The following is a description of a gene set: Human Gene Set: MYLLYKANGAS_AMPLIFICATION_HOT_SPOT_21 from publication Myllykangas S, Himberg J, Böhling T, Nagy B, Hollmén J, Knuutila S (PMID 16751803) studied in species Homo sapiens DNA copy number amplifications activate oncogenes and are hallmarks of nearly all advanced tumors. Amplified genes represent attractive targets for therapy, diagnostics and prognostics. To investigate DNA amplifications in different neoplasms, we performed a bibliomics survey using 838 published chromosomal comparative genomic hybridization studies and collected amplification data at chromosome band resolution from more than 4500 cases. Amplification profiles were determined for 73 distinct neoplasms. Neoplasms were clustered according to the amplification profiles, and frequently amplified chromosomal loci (amplification hot spots) were identified using computational modeling. To investigate the site specificity and mechanisms of gene amplifications, colocalization of amplification hot spots, cancer genes, fragile sites, virus integration sites and gene size cohorts were tested in a statistical framework. Amplification-based clustering demonstrated that cancers with similar etiology, cell-of-origin or topographical location have a tendency to obtain convergent amplification profiles. The identified amplification hot spots were colocalized with the known fragile sites, cancer genes and virus integration sites, but global statistical significance could not be ascertained. Large genes were significantly overrepresented on the fragile sites and the reported amplification hot spots. These findings indicate that amplifications are selected in the cancer tissue environment according to the qualitative traits and localization of cancer genes. Amplification hot spot 21: colocolized fragile sites and cancer genes in the 12q13-q21 region., and this is the list of marker genes: HMGA2, DDIT3, HOXC13, HOXC11, ATF1, CDK4